The following is a description of a gene set: Widened subarachnoid space studied in species Homo sapiens An increase in size of the anatomic space between the arachnoid membrane and pia mater. Human Gene Set: HP_WIDENED_SUBARACHNOID_SPACE, and this is the list of marker genes: WAC, MT-CO2, ATP11A, ALG2, MTRR, CUX1 (cut like homeobox 1), SNRPN (NCBI Gene Id 6638), NMNAT1, TSEN34, MPDU1, NARS1, IFT56, MT-CO1, MT-TL1, MT-ND5, ALG9, MT-TF, MT-ND1, MT-ND4, TSEN15, TSEN2, ALDH7A1, OTUD7A (NCBI Gene Id 161725), MT-TW, DNM1, AIFM1, MT-TS2, MT-CO3, ALG12, PIGA, PIGW, MT-ND6, PLPBP, GRIN1, MT-TH, SLC33A1, DTYMK, AHCY, CHD3, KIFBP, COX16, GCDH, SEPSECS, MT-TQ, TSEN54 (NCBI Gene Id 283989), WARS2 (tryptophanyl tRNA synthetase 2, mitochondrial), IDH1, ALG11